Given this list of marker genes THSD1, LARS2, RHD, MDFIC, CRB2, HNRNPK, here is a description of the gene set: An abnormal accumulation of fluid in which the heart is partially or completely surrounded by fluid that is seen in all views and the thickness of the fluid as observed by prenatal ultrasound is above age-dependent norms. Fetal pericardial effusion Human Gene Set: HP_FETAL_PERICARDIAL_EFFUSION studied in species Homo sapiens